Given this list of marker genes Fgf22, Klb, Fgf5, Fgf10, Fgf6, Flt3l, Fgf17, Fgf7, Fgfr3, Pik3r1 (phosphoinositide-3-kinase regulatory subunit 1), Fgf2, Sos1, Fgf16, Pik3ca, Fgf23, Fgf1, Frs2 (fibroblast growth factor receptor substrate 2), Fgfr1, Gab1, Pik3r4, Grb2, Pdpk1, Akt2, Fgf9, Fgf15, Them4, Pik3c3, Pik3r2, Fgfr4, Kl, Pik3cb, Fgf18, Trib3, Irs2, Fgf20, Tlr9, Fgf3, Fgf8, Ptpn11, Fgf4, here is a description of the gene set: IRS-mediated signalling Mouse Gene Set: REACTOME_IRS_MEDIATED_SIGNALLING studied in species Mus musculus